The following is a description of a gene set: The dendritic cell (DC) is a master regulator of immune responses. Pathogenic viruses subvert normal immune function in DCs through the expression of immune antagonists. Understanding how these antagonists interact with the host immune system requires knowledge of the underlying genetic regulatory network that operates during an uninhibited antiviral response. In order to isolate and identify this network, we studied DCs infected with Newcastle Disease Virus (NDV), which is able to stimulate innate immunity and DC maturation through activation of RIG-I signaling, but lacks the ability to evade the human interferon response. To analyze this experimental model, we developed a new approach integrating genome-wide expression kinetics and time-dependent promoter analysis. We found that the genetic program underlying the antiviral cell state transition during the first 18-hours post-infection could be explained by a single regulatory network. Gene expression changes were driven by a step-wise multi-factor cascading control mechanism, where the specific transcription factors controlling expression changed over time. Within this network, most individual genes are regulated by multiple factors, indicating robustness against virus-encoded immune evasion genes. In addition to effectively recapitulating current biological knowledge, we predicted, and validated experimentally, antiviral roles for several novel transcription factors. More generally, our results show how a genetic program can be temporally controlled through a single regulatory network to achieve the large-scale genetic reprogramming characteristic of cell state transitions. studied in species Homo sapiens Genes down-regulated in comparison of control conventional dendritic cells (cDC) at 1 h versus cDCs infected with Newcastle disease virus (NDV) at 1 h. from publication Zaslavsky E, Hershberg U, Seto J, Pham AM, Marquez S, Duke JL, Wetmur JG, Tenoever BR, Sealfon SC, Kleinstein SH (PMID 20164420) Human Gene Set: GSE18791_UNSTIM_VS_NEWCATSLE_VIRUS_DC_1H_DN, and this is the list of marker genes: KAT5 (lysine acetyltransferase 5), TAS2R14 (taste 2 receptor member 14), RBM45, LHX2, PTGFR, POLI, VPS35, ARHGAP27, ACADL, ZNF696, TSIX, CCDC77, RNF166, BLTP2, ZUP1, SLC35F1, RNASEL (ribonuclease L), SEPSECS, SCN11A, AGK, CTXN3, CREB3, DHX57, DTX3L, ZW10, AK5, LRFN5, FGF13, CFAP20, SQOR, CDK7, MAP4K4 (mitogen-activated protein kinase kinase kinase kinase 4), ARID3A, ZNF157, GTF3C3 (NCBI Gene Id 9330), CCDC34, RAB2B, HNRNPM, MTX3, ASNSD1, ALKBH1, LRRC19, CHRDL1, SERPINB4, ELMOD3, MEGF9, CADPS, SVOP, PCDHGB6, CDH18, KIAA0232, MVP, LINC02483, C6orf141, TFAP2C, CEACAM7 (CEA cell adhesion molecule 7), OR3A2, LCOR, SMPD3, NDUFA5, CDC42EP3, METTL4, MECOM, MED7, ZNF271P, SNRPA1, TIGD6, SLC30A7, MBIP, CCDC160, SENP2, CSGALNACT1, CCT7, EFTUD2 (elongation factor Tu GTP binding domain containing 2), HMGB3, PCDH8, CCDC190, ZNF680, DNAJC27, DGKG, SLC25A27, HYCC2, LRIF1, CHTOP, FNBP4, TTC8, DHRS7B, ZNF616, AKNAD1, LY6S-AS1, OPA1, NIP7, PKN3 (NCBI Gene Id 29941), BACH1, TBC1D31, TGIF1, HSPA12A, ZNF620, SLC25A3P1, DPF3, ANKRD30B, CLMP, IRAK1BP1, TBX5, CKMT2-AS1, MYH13, ENPP3, NAP1L5, RAD21-AS1, RIPK4, DCAF13, ATP6AP2, HTN1, ALAD, GSTM5, ZNF207, LINC00955, SLIT2-IT1, EIF5A2, GPATCH2L, SNX1 (NCBI Gene Id 6642), BEST4, COG3, UCK2, PI4K2B, FAM168B, UGGT2 (UDP-glucose glycoprotein glucosyltransferase 2), DESI1, FKTN, MDGA2, PRPF3, CA10, MYO1A, POC5, SLC20A2, CAPN7, BAP1, SLC19A2, SPMIP10, COG7, COA1 (cytochrome c oxidase assembly factor 1), METTL3, PGLYRP4, LRRCC1, PAFAH1B2, TMEM72-AS1, ZDHHC13 (NCBI Gene Id 54503), ACO2, TMEM213, DHFR2, KIF9-AS1, BNIP1, BRWD3, PLAC8L1, ZNF805 (zinc finger protein 805), MIA3, GIP, CENPQ, NAA35, MYO5C, CABP2 (NCBI Gene Id 53597), CYLC2, IRS4, GFM1, ZFYVE26, EMC2, SPTLC2, ZSCAN23, DMRTC2, CRYBB2P1, LINC00029, SPRYD4, ACVR2B-AS1, GRAMD1C, CLHC1, VPS35L, IRF2BPL, STYX, SIGLEC6, SRR, TRMT13, TOR1AIP1, FUBP3, SMIM8, CTAGE9, CCDC122, SPMIP4, PCDH11X, PPP2CB, DNAI3, TRIM23, RIPK3, ETAA1